The following is a description of a gene set: part of: TCF dependent signaling in response to WNT electronically inferred by orthology from the curated human pathway This event has been computationally inferred from an event that has been demonstrated in another species.<p>The inference is based on the homology mapping from PANTHER. Briefly, reactions for which all involved PhysicalEntities (in input, output and catalyst) have a mapped orthologue/paralogue (for complexes at least 75% of components must have a mapping) are inferred to the other species. species: Mus musculus Reactome Pathway: Regulation of FZD by ubiquitination, and this is the list of marker genes: Fzd8, Rnf43, Lgr5, Lrp5, Rps27a, Ubb, Wnt3a, Fzd6, Znrf3, Fzd4, Igfals, Rspo1, Rspo3